The following is a description of a gene set: from publication Cui A, Huang T, Li S, Ma A, Pérez JL, Sander C, Keskin DB, Wu CJ, Fraenkel E, Hacohen N (PMID 38057668) Cytokines mediate cell-cell communication in the immune system and represent important therapeutic targets. A myriad of studies have highlighted their central role in immune function, yet we lack a global view of the cellular responses of each immune cell type to each cytokine. To address this gap, the authors created the Immune Dictionary, a compendium of single-cell transcriptomic profiles of more than 17 immune cell types in response to each of 86 cytokines (>1,400 cytokine-cell type combinations) in mouse lymph nodes in vivo. A cytokine-centric view of the dictionary revealed that most cytokines induce highly cell-type-specific responses. For example, the inflammatory cytokine interleukin-1β induces distinct gene programmes in almost every cell type. A cell-type-centric view of the dictionary identified more than 66 cytokine-driven cellular polarization states across immune cell types, including previously uncharacterized states such as an interleukin-18-induced polyfunctional natural killer cell state. Mouse Gene Set: CUI_CDC2_IL27_RESPONSE_DN species: Mus musculus Genes negatively differentially expressed in cell type: cDC2 (conventional dendritic cell type 2) upon treatment with cytokine: IL-27 in mouse lymph nodes in vivo., and this is the list of marker genes: Dusp1, Zfp36, Atf3, Pmaip1, Klf2 (NCBI Gene Id 16598), Pdcd4, Ier2, Fos, Klf4, Ccl9, Slc44a1 (solute carrier family 44, member 1), Egr1, Btg2, Jun, Ddx5, Tsc22d3, Fosb